The following is a description of a gene set: species: Homo sapiens Bleeding within the fundus of the eye. Human Gene Set: HP_FUNDUS_HEMORRHAGE Fundus hemorrhage, and this is the list of marker genes: LAMB2, TREX1, CFI, IKBKG, MYD88 (NCBI Gene Id 4615), EFEMP1, ERCC6, ERCC8 (ERCC excision repair 8, CSA ubiquitin ligase complex subunit), ESAM, CFHR1, CFHR3, ATP6V1E1, DNM2, COL4A1, ATP6V0A2, APOE, TERC, XYLT1, TERT, DST, GCDH, ABCC6, ATP6V1A (ATPase H+ transporting V1 subunit A), HMCN1, XYLT2, SBDS, CFH, PRF1, IFNG, ENPP1